The following is a description of a gene set: from publication Cui A, Huang T, Li S, Ma A, Pérez JL, Sander C, Keskin DB, Wu CJ, Fraenkel E, Hacohen N (PMID 38057668) Genes negatively differentially expressed in cell type: cDC2 (conventional dendritic cell type 2) upon treatment with cytokine: LIF in mouse lymph nodes in vivo. Mouse Gene Set: CUI_CDC2_LIF_RESPONSE_DN species: Mus musculus Cytokines mediate cell-cell communication in the immune system and represent important therapeutic targets. A myriad of studies have highlighted their central role in immune function, yet we lack a global view of the cellular responses of each immune cell type to each cytokine. To address this gap, the authors created the Immune Dictionary, a compendium of single-cell transcriptomic profiles of more than 17 immune cell types in response to each of 86 cytokines (>1,400 cytokine-cell type combinations) in mouse lymph nodes in vivo. A cytokine-centric view of the dictionary revealed that most cytokines induce highly cell-type-specific responses. For example, the inflammatory cytokine interleukin-1β induces distinct gene programmes in almost every cell type. A cell-type-centric view of the dictionary identified more than 66 cytokine-driven cellular polarization states across immune cell types, including previously uncharacterized states such as an interleukin-18-induced polyfunctional natural killer cell state., and this is the list of marker genes: Pabpc1, Foxp1, Prkcd, Nr4a1, Hspa1a, Ddx5, Fosb, Cbl, Btg2, Trappc5 (NCBI Gene Id 66682), Mcemp1, Neat1, H2-DMa, Ncf1, Nr4a2, Zeb2 (zinc finger E-box binding homeobox 2), Myadm, Cybb, Pmaip1, Cd180, Dnajc7, Il6ra, Cox7a2l, Zfp36, Ccrl2, Ier5, Klf2, Fos, Txnip